Given this list of marker genes Fgf1, Fgf16, Fgf8, Fgf18, Kras, Grb2, Fgf4, Sos1, Hras, Fgf17, Fgf20 (fibroblast growth factor 20), Fgf5, Shc1, Fgf9, Fgf23, Fgf2, Fgfr3, here is a description of the gene set: species: Mus musculus SHC-mediated cascade:FGFR3 Mouse Gene Set: REACTOME_SHC_MEDIATED_CASCADE_FGFR3